Given this list of marker genes APOA2, KIF5C, CDC42, PCSK9, NR1H2, APOA1, ABCA12, here is a description of the gene set: Human Gene Set: GOMF_APOLIPOPROTEIN_RECEPTOR_BINDING Binding to an apolipoprotein receptor. studied in species Homo sapiens